Given this list of marker genes Furin, F2, Pros1, Bglap2, Ggcx, Proc, F10, F9, Gas6, Proz, F7, here is a description of the gene set: Mouse Gene Set: REACTOME_GAMMA_CARBOXYLATION_TRANSPORT_AND_AMINO_TERMINAL_CLEAVAGE_OF_PROTEINS Gamma-carboxylation, transport, and amino-terminal cleavage of proteins studied in species Mus musculus